The following is a description of a gene set: Human Gene Set: MIR8065 from publication Chen Y, Wang X (PMID 31504780) Genes predicted to be targets of miRBase v22 microRNA hsa-miR-8065 in miRDB v6.0 with MirTarget v4 prediction scores > 80 (high confidence targets). studied in species Homo sapiens, and this is the list of marker genes: SLC6A5, OIT3, INSR, KAT6A, CDK9, VEZF1, NECTIN2, MAX, SGIP1, ALDH2, ZKSCAN3, ZNF704, TUBGCP5, ABCB11, DUSP4, PLEKHB2, KDM7A, STRBP, PHB2, POLR3F, NBN, DEPTOR, PTPN20, ZNF354A, RNF111, SPAG1, FAR1, GANC, NLRP11, HIC2, FMO5, ARHGAP29, HYCC2, ENAH, CTDSPL, TNFRSF19, RNF41, ZNF286A, LIN54, AAK1, TSPEAR, PTAFR, CBLN1, MED20, NPC1L1, PROS1, PDE8B, ATP11C, ACAT2, RNF149, MBNL1, SVIP, KLHDC10, PLCB2, NUDT19, SPC25, NCOA2, NCL, SERPINA10 (serpin family A member 10), GUCY1A2, ALG13, FGD1, HLTF, FOXH1, PIKFYVE, NR6A1, LINC03106, SIGLECL1 (SIGLEC family like 1), ADAT1, DMRT2, SH2D4B, FKBP3, NOLC1, PDZRN4, CHD2, ELMOD2, CNBD2, BTC, CLCN5, EML4, PPT1, LRRC31, PRR27, PSMC4, CCNE2, TOP1, RAB11FIP1, EFCAB14, ST6GALNAC3, SOX8, CRBN, KLHL28, THRB, SHISA9, SSR3, CHST14, SPTSSB, RNF212B, PURA, LYRM4, DLG2, SF3B1, PAK3, RIOK2, LRCH1, EYS, CYBRD1, MRS2, ATG7, NR3C1, VTCN1, CCDC90B, NANOS1, ZEB2, YY1, BAZ2B, ZBTB4, GSTM4, RHOH, KCNT2, CACYBP, RIMBP2, LACC1, PRELID3B, NIT1, STIMATE, NUCKS1, SMURF2, ZNF286B, EIF2AK2, PPP3CA, PDE6D, DNM1L, FDFT1, LUC7L3 (LUC7 like 3 pre-mRNA splicing factor), MARS2, IL1RL2, KLF8, AS3MT, HDAC4, CELF2, HTR7, COL4A5 (NCBI Gene Id 1287), ABHD5, ABL2, SHROOM3, ADAMTS6, RASAL2, SULT1E1